The following is a description of a gene set: from publication Browne EP, Wing B, Coleman D, Shenk T (PMID 11711622) The effect of human cytomegalovirus (HCMV) infection on cellular mRNA accumulation was analyzed by gene chip technology. During a 48-h time course after infection of human diploid fibroblasts, 1,425 cellular mRNAs were found to be up-regulated or down-regulated by threefold or greater in at least two consecutive time points. Several classes of genes were prominently affected, including interferon response genes, cell cycle regulators, apoptosis regulators, inflammatory pathway genes, and immune regulators. The number of mRNAs that were up-regulated or down-regulated were roughly equal over the complete time course. However, for the first 8 h after infection, the number of up-regulated mRNAs was significantly less than the number of down-regulated mRNAs. By analyzing the mRNA expression profile of cells infected in the presence of cycloheximide, it was found that a minimum of 25 mRNAs were modulated by HCMV in the absence of protein synthesis. These included mRNAs encoded by a small number of interferon-responsive genes, as well as beta interferon itself. Cellular mRNA levels in cytomegalovirus-infected cells were compared to the levels in cells infected with UV-inactivated virus. The inactivated virus caused the up-regulation of a much greater number of mRNAs, many of which encoded proteins with antiviral roles, such as interferon-responsive genes and proinflammatory cytokines. These data argue that one or more newly synthesized viral gene products block the induction of antiviral pathways that are triggered by HCMV binding and entry. Genes down-regulated in primary fibroblast cell culture after infection with HCMV (AD169 strain) at 20 h time point that were not down-regulated at the previous time point, 18 h. species: Homo sapiens Human Gene Set: BROWNE_HCMV_INFECTION_20HR_DN, and this is the list of marker genes: AXL, MT1B, ITGA3, MIR3648-1, SLC35E2B, KRT34, SRPX2, LPP, CCN2, FST, LTBP1, CAP2, CHMP2A, DIAPH2, RHOBTB3, MAP3K5, DST, SYT11, KIAA1549L, H4C3, PTGFR, TNFRSF14, HMMR, SLC22A4, ATXN10 (ataxin 10), TRAF3IP2, ROR2, TMCO6, TNKS, SIPA1L1, TMEM158, GLRX, FILIP1L, ADD3, IGF2BP3, GSTO1, FRY, FOLR3, SYNE1, ACP3 (acid phosphatase 3), TGFBR3, COL1A2, OGA, PCLAF, ANXA2, FBXL2, MGLL, CRADD, RND3, TBC1D8, RUNX1T1, HMBS, ACAA1, ANXA1, FARP1, TRIO, ETHE1, NQO1, ATP2B1, REV3L, SERPINB2, FGF2, RRAS2, TRIM2, ALDH6A1, RHOBTB1, TPD52L2, ACO1, SVIL, LRRC15 (NCBI Gene Id 131578), NMT2, ANXA2P1, DENND2B, BBS4, VPS41, DNASE1L1, PMP22, PTPN13, TFPI, PKIG, LILRA1, NR1D2, F2R, MBNL1 (muscleblind like splicing regulator 1), AHR, PDE4B, ADIRF, ECH1, AKT3, VCL, BICC1, MACF1, WIPI1, ATP13A3 (NCBI Gene Id 79572), BUB1B, GBE1, ME3, TRIM22, RABGAP1L, RGS4, SEPTIN11, TRAM2